Given this list of marker genes ANXA5, WDR5, POLQ, GGCT, CIT, SHCBP1, TBC1D10B, ACAT2, PAF1, TRAV8-2, MXD3, SKA3, NUP50, RCC1, H2AC14, ERAP1, PI4KA, CHTF18, STRBP, NUP205, ANKMY1, MZT1, MPP1, SGO1, ZNF85 (NCBI Gene Id 7639), KNL1, FANCA, SERPINF1, RNASEH2A, KIF20B, PHC1, PDS5B, THOC6, GTSE1, STMN3 (stathmin 3), PPIF, RBBP8, MAGOHB, STRN, BRD8, ALMS1, H2AC15, H2AC11, MAP3K20, H3C15, KIF18A, SPTSSA, VRK1, TNPO3, HYLS1, DSN1, HMCES, SAAL1, TPGS2, ERAP2, TMEM106C, HMGXB4 (HMG-box containing 4), HIRIP3, UBL7-DT, H2BC3, ACYP1, FANCD2, EXOSC8, RPP30, CDC6, CKAP2, WEE1, SKA1, TRIM28, KIF18B, ZNF367, AAAS, EXOSC6, TAB2, DYNLT2B, SLC16A1, TAF5, LARP4, JUP, CENPW, TYMS, EMC9, GTF2A1, TRAIP, TUBB2A, NIPSNAP3A, BUB1B, H1-5, CTCF, HSD17B8 (NCBI Gene Id 7923), CBX1, FAM111A, ASF1B (NCBI Gene Id 55723), ZFYVE19 (zinc finger FYVE-type containing 19), BICD2, LINC01572, USP37, SIRPG, COQ10A, FIGNL1, CYTH2, OXCT1, NIN, H3C7, GNL1, IFNGR2, PSRC1, AIDA, STAT1, ALDH7A1 (aldehyde dehydrogenase 7 family member A1), PHF7, PSMC3IP, PABIR3, UQCRHL, CCNG2 (cyclin G2), H2BC15, MSH3, CTDSPL2, GLE1, ZNF93, PGD, VKORC1L1, ZNF66, CISH, BARD1, GINS3, SLF1, MSH2, DHRS4L2, FOXJ2, SGO2, ZEB1, CCHCR1, HDGF, PGRMC1, PMM1, CMTM7, MAD2L1, DLEU2, POLD1, NXPE3, MELK, TEX30, TK1 (thymidine kinase 1), ZFAND4, MMGT1, IGFBP2, ADK, CCDC15, HMGB3, WDR76, MCM6 (minichromosome maintenance complex component 6), PRPS1, FCGRT, H3C8, SYNE2, NSMCE2, CALHM6, PIGX, EED, ACD, H2BC18, CMTM8, NSD2, CDK5RAP2, SMC5, NEMP2, HAUS4, CENPT, IER3, SH3GLB2, RNF144A, CCNG1, H4C16, WDR54 (WD repeat domain 54), SVIP, CDCA3, DNA2, GAR1, POLA2 (DNA polymerase alpha 2, accessory subunit), ATP6V0E2, MID1IP1, H2AC12, NDC80, H2AC8, DPM1, PSMD10, ORC3, MCM8, DEPDC1, CDCA8, SRGAP2, SLC44A1, RFC3, MOV10, ANAPC15 (anaphase promoting complex subunit 15), CCDC82, ERVH48-1, RPL39L, CEP120, RUVBL2, MAP4K2, C21orf58, MYEF2, CDC20, SLC25A1, KIF22, SLC19A1, NUP107, RANBP3, NRM, WBP4, DLG1, CCNA2, GNB5, MBD4, TMEM143, PRPSAP1, XRCC1, HLTF, SEH1L, PAGR1 (PAXIP1 associated glutamate rich protein 1, NCBI Gene Id 79447), ID1, CENPU, TEDC1, FIRRM, PDSS1, TOMM70, TRIP13, STIL, SUV39H2, PBRM1, FANCG, ATP1B3, LINC02446, ING2, CHMP4B, NCAPH2, CLN6, CTPS1, CNTROB, ARL4D, MCMBP, TIPIN, PAXBP1, PCNT, BAG2, SCMH1, LRRC58, AP1B1, H4C6, CIP2A, HPGD, C19orf48P, MFGE8, BCOR, CENPJ, HACD3, UBAP2, LINC02273, SNRNP25, ELP5, NCAPH, SPC25, MTHFD2 (methylenetetrahydrofolate dehydrogenase (NADP+ dependent) 2, methenyltetrahydrofolate cyclohydrolase), DHFR, MIS18A, FAF1, MYCBP, SIAH1, UBE2S, STAG3, CD8B, ZNF714, TIMM10, EBP, KPNA2, SMCO4, TRAPPC14, GBP1, SLC7A1, GPANK1, ANKRD36B, MYBL2, H4C2, MYO19, EPB41L2, AP1S1, PRC1, NAB2, CCDC88A, SNRNP48, NUDT15, GMPPB, CMC2, BICDL1, POP7, POLH, PEDS1, TOB1, RFC4, MRPL35, ANKRD36C, ING1, ORC1, RAB25, NUF2, THEMIS, GPA33, NUDT1, HDGFL2, EEFSEC, FKBP5, NUSAP1, NTAN1, SGK1, HILPDA, MASTL, MRPL39, HEBP2, CDK19, PLK4, ZDHHC12, ATAD2, LRRC45, CEP63, GBA1, NCAPG, CNOT10 (NCBI Gene Id 25904), MAD2L2, TFDP1, C1orf35, SNN, CMSS1, SUZ12, HAUS2, RHNO1, CBX5, NUP35, CD4, NCAPD2, RIMKLB, E2F1, UBXN11, BUD13, C5orf34, PRXL2B, HYI, BCL11B, TRMT10C, BRCA2, BRIP1, FAM76B, NUP160, ANKRD36, H3C3, RCAN3, UBE2T, MCM10, NREP, CENPP, UBE2Q1, CEP192, LINC01550, SHMT1, PRIM1 (NCBI Gene Id 5557), C8orf88, RMI2, THOC1, TROAP (trophinin associated protein), ARL6IP1, CHAMP1, GTPBP8, FAM13A, DPAGT1, PPP2R5D, DGCR8, RIF1, RBL1, LRR1, GLRX5, MCM2, ZNF524, SARNP (NCBI Gene Id 84324), MED29, TBL1XR1, DTL, ZC3H3, CCNE2, ALDH16A1, GRN, KNTC1, SREBF1, PCBD2, RBM23, FABP5, H4C8, WDR6, PARP2, ARHGAP11A, RETREG1, RAD54L, RBM15, PBK, H3C10, DNAJC9, RFWD3, IPO5, ICOS, SRGAP2C, SPAG16, ARMC1, KNSTRN, GSTM1, XPO1, ANKRD26, PPP4R1, CHD7, MBNL3, CBFB, PTP4A3, SASS6, LMNB2, CCNB2, LMF2, POLD3, CHEK1, REC8, MCUR1, CD28, H2AC4, USP1, NEDD1, WDR62, CENPL, MTRFR, STK32C, CEP85, CDCA7, CHD1L, MAST4, ZWINT, SNIP1, UBR7, CCDC14, PRPF19, NUDT8, SRGAP2B, CRNDE, NEK2, DCAKD, ST3GAL3, HSPA2, FEN1, CLSPN, SLC35E3, UBE2C, ACAD9, TIMM21, ZNF326, NCAPG2, PARPBP, BLM, ZGRF1, CDKN2C, INTS4, TPX2, JPT2, PTTG1, CCNF, CHAF1B, ACTL6A, DESI2 (NCBI Gene Id 51029), APOO, GLA, MTFR2, TIMELESS, HNRNPUL2, TMEM14A, UQCC3, GINS2, ACOT7, RCOR1, DYNC2I2, CKAP5, ESCO2, CDV3, SMPD4, C4orf46, H2BC11 (H2B clustered histone 11), CCDC34 (coiled-coil domain containing 34), KCTD18, MND1, LIG1 (NCBI Gene Id 3978), GSS, CDCA2, POLA1, TMEM237, LMNB1, SMC6, TMEM204, PRR11, RAD1, SPC24, SMARCA4, STOX1, KMT5C, STK24, SERINC5, SOD2, PARP16, USP39, IL23A, CEP135, H2BC13, LIN54 (NCBI Gene Id 132660), ARMH1, TUBG1, LIMK2, SAC3D1, ANKRD54, RFC2 (NCBI Gene Id 5982), MRGBP, MICB, CENPO, TRABD2A, MED13, SPRTN, CHAF1A, CDC25C, ARL6IP6, TRIOBP, CAMK2G, SLC43A3 (NCBI Gene Id 55543), CEP152, MKKS, HAT1, RAD51C, CENPH, ZWILCH, TADA2A, AARS1, MCM4, SCAI, RCCD1, ECT2, POT1, CENPN, RAD51AP1, SIT1, CDCA7L, OIP5, KIF11, NFYB (nuclear transcription factor Y subunit beta), CCP110, GAMT, ASH2L, MAP3K1, CDCA4, CTNNAL1, PXMP2, GUSB, FBXO5, WDHD1, MMAB, CHI3L2, CFAP68, SLC25A14, ODF2, TTF2, APOLD1, DBF4, DTNB, KIF2C, RANGAP1, BAZ1B, SIN3A (SIN3 transcription regulator family member A), CDCA5, R3HDM1, ATXN3, PHGDH, KIF4A, EEF1AKMT2, SPICE1, CERS6, RNF168, CD6, NRF1, MUTYH, POLD2, IFI27L1, MRPL48, RRM1, LETM1, RBM15B, G2E3, CKS1B, FOXM1, KIF14, KIF15, ACTN1, TDP1, MMS22L, GOT1, BCL7A, SEPHS1, PMS1, NCAPD3, CDC45, NCOR2, CHRAC1, GSPT1, SSBP2, CCDC18, BRCC3, ATAD5 (NCBI Gene Id 79915), FBXL5, INCENP, BAG4, MIS18BP1, H4C4, PDLIM7, BDH1, NNT, CEP57L1, PRIM2, HOOK1, ZCCHC8, HAUS5, CNPY4, CEP131, NFATC2IP, H4C12, LYRM7, SPAG5, MFSD14CP, IDH3A, PIDD1, PSAT1, MSH6, AFG2A, RACGAP1 (Rac GTPase activating protein 1), DIAPH3, JADE1, PCK2, ITPRID2, MAP4K4, CNTLN, IL6ST, RNF138, TRIM59, CDK1, SCML1, MLST8, TIFA, CD5, PAK1, E2F8, ITGB3BP, GINS4, NANS, TCEA3, KATNBL1, FAM111B, FOXRED1, RFC5, AP3M2, HAUS6, ADPRM, ABHD12, FAM98B (family with sequence similarity 98 member B), CENPF, RRM2, FH, ENOSF1, PRPS2 (phosphoribosyl pyrophosphate synthetase 2), AUTS2, UHRF2 (NCBI Gene Id 49857), FAM72A, BUB1, UMPS, GRAPL, FBLN2, SERTAD2, CENPA, INTS7, E2F7, KMT5A, NEMP1, MCEE, ALYREF, COMMD4, FAM72C, EZH2, ARHGAP33, TOP2A, PLK1, PDE3B (phosphodiesterase 3B), UBALD2, PRR3, KIAA0586, ARID2, AURKA, SRPK1, YEATS4, GPN3, WRAP53, PLCL2, USP5, H2AC16, RDM1, ARHGEF39 (NCBI Gene Id 84904), AHCYL1 (NCBI Gene Id 29039), SKA2, HELLS, HAUS1, DLGAP5, VRK3, DEPDC1B, CSTF2, MTHFD1, THOC5, HAUS8, NR2C2, DSCC1, BACH2, CFAP20, PGP, SLFN11 (schlafen family member 11), MCM7, TTF1, AIG1, RNF26, SLC2A4RG, LRRN3, RECQL, HMMR, SKP2, PKNOX1, KIFC1, MCM5, SUV39H1, CNTRL, ESPL1, SMC2, ASF1A, ASRGL1, PLEKHG2, BAG3, HJURP, MGME1, DDTL, FAM72B, AHCY, FAHD2A, CASP6, BRAP, UHRF1, H3C2, NUP188, METTL4, MCM3, CDT1, DTYMK, FANCI, AGPAT3, TPRKB, CD200R1, DDB2, THOP1, NAA50, METTL2A, MACROD1, MKI67, CDK2 (NCBI Gene Id 1017), N4BP2, RAB3IP, CMPK2, SPDL1, BRCA1, H1-1, ORC6, EXOSC9, HADH (NCBI Gene Id 3033), PKMYT1, MPHOSPH9 (NCBI Gene Id 64797), POC1A, CDC27, CENPK, EXOG, NUP37, C20orf96, CEP43, MYL6B, DONSON, RUSC1, TOPBP1, INIP, MPDU1, COPS8, H2BC14, PAICS, UBIAD1, ANLN (NCBI Gene Id 54443), DCLRE1C, SYCE1L, CASP2, PCLAF, CHEK2, CCNB1, CCNE1, CSTF1, SELENOI, CSE1L, TCOF1, CEP295, PSMG1 (NCBI Gene Id 8624), SLC29A1, FAM83D, GGH, DCAF16, MRM2, ATRIP, RTKN2, KCNA3, C4orf33, TMEM41B, MORF4L2, AURKB, KDM1A, ENTPD6, H2AC20, RMI1, PGM2L1, THAP3, EXOC6, CDC5L, SIGMAR1, REEP4, CD248 (NCBI Gene Id 57124), TBL1X, EPOR, TRAF2, DYNLL2, RECQL4, CDKN3, INAFM1, BCL2L12, RFX2, TUBD1, MAL, CASP8AP2, PCNA, EXO1, ARL17A, PM20D2, CENPQ, H2AC17, H2BC9, GMPS, NET1, SVBP, MMD, SAMD1, TCF19, NUP155, TTK, CKAP2L, CEP55, ZNF83, PPCDC, CNOT9, H2AC21, PIMREG, INF2, CUX1, PSMD14, H2AC13, MTHFD2L, H4C1, ITGA6, CENPM, GRAP, ASPM, PAQR4, TASP1, ILVBL, ZW10, NTMT1, GMNN, PAFAH1B3, TMEM14C, A1BG (NCBI Gene Id 147680), ABI2, BCL11A, H2BC4, PUSL1, NENF, DDX11, HCFC1R1, RFLNB, TMEM97, GTF3C5, H2BC7, CAPG, NEIL3, KIF23, BORA, TOE1, BOLA3, CD40LG, MICU1, DBNDD2, NUP58, IGF2BP3, PHACTR4, H3C14, BIRC5, PRADC1, MLH1, PHF19, TACC3, POLE, NCKIPSD, PDZD11, SUSD3, RCC2, DIPK1A, FANCL, LDLR, TRIM69, KIF20A, E2F2, PPT1, CENPE, FZR1, PDK1, SFI1, NPAT, here is a description of the gene set: Human Gene Set: HE_LIM_SUN_FETAL_LUNG_C4_CYCLING_T_CELL studied in species Homo sapiens from publication He P, Lim K, Sun D, Pett JP, Jeng Q, Polanski K, Dong Z, Bolt L, Richardson L, Mamanova L, Dabrowska M, Wilbrey-Clark A, Madissoon E, Tuong ZK, Dann E, Suo C, Goh I, Yoshida M, Nikolić MZ, Janes SM, He X, Barker RA, Teichmann SA, Marioni JC, Meyer KB, Rawlins EL (PMID 36493756) Cycling T